Given this list of marker genes DTNA, DDI1, TOR1AIP1, LGSN, FAM131B, ARL4C, POU2F2, CALML4, UHMK1, KIAA1191, SH3PXD2A, B3GLCT, LPGAT1 (NCBI Gene Id 9926), CEP85L, MAGI3, ZNF682, ZNF558, ZNF728, ADAM22, ZNF559-ZNF177, ONECUT2, ZFP14, USP37 (ubiquitin specific peptidase 37), BCLAF1, RAPH1, RIN2, ADRB2, ZNF713, TMEM245, SH3TC2, ZFP90, MEF2A, TRAK2, GTDC1, ANO3, FRMPD4, SMIM14, SELENOT, TRIM9, TOB2, TBCEL, RDH12, MBOAT2, CDR2L, ZSWIM6, HDAC8, IL17RD, HNMT, ACSM2B, GPATCH2L, FAF2, ZNF91, PTGR3, ZNF468, PCSK2, VGLL3 (NCBI Gene Id 51159), EPS8, ZNF107, ZNF57, ZNF181, SLC8A3, DNAJB9, DOK6, LENG8, IDE, DGKG, NNT, SLC12A6, SYNJ2BP, ZNF816, ZNF730, MBNL1, PDK3, CLMP, CNNM4, TMEM87A, PSD3 (NCBI Gene Id 55358), ADGRF1, ZNF708, KCNJ3, ZNF502, FUT9, TPT1, PIP5K1B, VANGL1, MAP1B, ACSM2A, ARF6 (NCBI Gene Id 63379), C22orf46P, SEMA3A, VPS13C, SLC39A8, KIAA1549L, NF1, ZNF718, MAFK, ZFP1, ZNF763, ZBTB7A, ZNF765, ZNF701, SEC61B, TSC22D2, DIRAS3, LDB2, IQCJ, PLXNA4, SLC17A3, HOXC6, ZNF195, ALDH2, EP300, CYB561D2, THG1L, TAF11, DCX, CCDC88A, SGMS1, ZNF415, ZNF578, FAM120A, ZNF99, ZNF117, ZNF761, CDH19, TRIM71, ZNF676, TMEM170B, SLC5A12, PGF, USP10, NXPH2, PARD3B, LTN1, CSGALNACT2, ANKRD28, ZNF317, FOXK1, GSE1, ZNF716, ZBTB18, PPP5D1P, ZNF670, PPP6R3, B3GALNT2, ASCL1, LONRF3, PAPPA, MYCL, BTRC, ZNF600, RBMS3 (NCBI Gene Id 27303), PHYHIPL, ZNF714, ARL15, SRP19, ENTPD1, SLC7A11, MSS51, CADM2, SPOP, KRIT1, MBNL3, ZNF135, CHD9, ZNF124, ZNF844, ZNF808, TM4SF18, ENPP1, KLHL5, ZNF705D (NCBI Gene Id 790967), PDE7B (NCBI Gene Id 27115), IKZF1, HLA-DOA, ZNF257, ZNF90, CASP3, FANCL, GATM, GCLM, SLC30A7, SBNO1, CDK6, SOBP, ZNF138, SLC6A2, RAB27B, NEDD4L, ZNF440, TTC31, KMT2A, SRXN1, ANKH, LRRC7, SIRT3, RSBN1, SLAIN2, ZNF594, EVC, SLC38A1 (NCBI Gene Id 81539), RIMKLB, RNF148, RPP30, MID1, CLEC4A, TPM3, PRKCB, LACC1, RBFOX2, CHD5, NFXL1, AUTS2, PATE1, ZNF136, ZNF208 (zinc finger protein 208), GNB1, PLD5, CAVIN2, PPARGC1B, SFTPB, CNKSR2, TBL1XR1, SLC4A8, ARK2C, MYO3B, FAM78A, EMX2, PPRC1, REEP3, RIMBP2, ZNF493, AAK1 (AP2 associated kinase 1), GPC6, ZNF845, PALM2AKAP2, PEG10, ZNF426, ZNF544, SIKE1, LSAMP, PHLPP1, PLXNA2, ATP8A1, CLVS2, MYT1, SLAIN1, SPRY3, TMEM151B, ZNF302, ATP6V1C1, ZNF721, PDE4D, ZMYND8 (NCBI Gene Id 55497), SLC22A15, RAD54L2, SMIM21, ZDHHC3 (zinc finger DHHC-type palmitoyltransferase 3), SERTM1, ABCC9, PTGES3, FGF23, NEURL1B, SPINK7, ZNF611, BCL11A, ZNF888, ZNF557, LPP, GALNT15, C1QTNF3, ZNF420, RPS6KA6, KCNT2, NFIX, ZNF569, ZFHX2, ZNF189, VIP, RTN4RL1, CUL3, DLAT, PMEPA1, ZNF813, SENP3, LTA, RNF213, ZNF28, SCAI, ADAMTS1, PPP2R5B (NCBI Gene Id 5526), CDK12, SSUH2, ZNF655, COPS6, PRTG, ZNF711, EGR3, MAP3K2, TCHHL1, TNRC6B, HAO1, MTMR2, GCFC2, TGFBRAP1, CDON, BNC2, STON2 (stonin 2), ZNF439, ZFP36L1, MEX3A, ZNF268, ITGA4, DLG3, IL20RB, ZSCAN22, ZBTB20, ZNF207, EDA, ACSL3, ZNF626, QRSL1, BLZF1, DCP1B, ENC1, PURA, here is a description of the gene set: Genes predicted to be targets of miRBase v22 microRNA hsa-miR-4768-5p in miRDB v6.0 with MirTarget v4 prediction scores > 80 (high confidence targets). species: Homo sapiens Human Gene Set: MIR4768_5P from publication Chen Y, Wang X (PMID 31504780)